The following is a description of a gene set: species: Homo sapiens A multi-subunit complex deposited by the spliceosome upstream of messenger RNA exon-exon junctions. The exon-exon junction complex provides a binding platform for factors involved in mRNA export and nonsense-mediated mRNA decay. Human Gene Set: GOCC_EXON_EXON_JUNCTION_COMPLEX, and this is the list of marker genes: PNN, PYM1, CASC3, UPF2, EIF4A3 (eukaryotic translation initiation factor 4A3), UPF3B, R3HCC1L, MAGOHB, SMG6, RNPS1 (RNA binding protein with serine rich domain 1), RBM8A, SRSF1, ALYREF, SAP18, ACIN1, UPF1, THRAP3, TDRD3, CCDC9, UPF3A, MAGOH